The following is a description of a gene set: species: Homo sapiens Any process that results in a change in state or activity of a cell or an organism (in terms of movement, secretion, enzyme production, gene expression, etc.) as a result of a stimulus reflecting the presence, absence, or concentration of oxygen. Human Gene Set: GOBP_RESPONSE_TO_OXYGEN_LEVELS, and this is the list of marker genes: WTIP, MAP3K7, BMP7, MIR34A, LOXL2, CIAO3, NDRG1, TGFBR3 (NCBI Gene Id 7049), FZD4, FMN2, ACAA2, SCAP, MDM4, BNIP1, VEGFC, DRD2, ANGPT2, TBL2, EP300, NOS1, VEGFB, MT-CO1, PGF, ITPR1, LCN2, ANGPT4, DIO3, CAPN2, PTPN1, POLB, SLC11A2, F7, TGFB2, HMOX2, NOTCH1, ADA, DDAH1, BIRC2, INHBA, TFRC, TMBIM6, PML, CAV3, ADSL, TRPC6, HP1BP3, PPARG, CYBA, BECN1, CPEB4, COMT, COL1A1, PDK3, COMMD1, SLC29A1, TMEM199, LMNA, MT-ND1, DPP4, E2F1, RORA, VEGFA, FOXO1, ADORA1, BCL2, AK4, BNIP2, HIGD1C, HYOU1, PRKAA1, MAP1LC3A, EGR1, ADO (2-aminoethanethiol dioxygenase), HSP90B1, MGARP, CD38, CRYAB, SMAD3, MIR223, PLEKHN1, CREBBP, SOD2, PARP2, SCN2A, STUB1, MIR448, ALAS1, MTOR (NCBI Gene Id 2476), CCNA2, MTCO2P12, NGB, BAD, CA9, RYR1 (NCBI Gene Id 906), VASN, TH, ERO1A, S100B, HIF3A, PLAT, MIR214, ENDOG, AQP1, SLC2A8, PENK, CBS, ITGA2, SIRT2, PKLR, UCN3, TNF, ABCB1, ADAM15, FAS, CASP3 (caspase 3), SLC2A4, FGFR2, RPTOR (NCBI Gene Id 654218), BNIP3L, TP53, HIGD1A, MSTN, ATP1B1, CREB1, IRAK1, MALAT1, MIR762, APAF1, CBFA2T3, CYP1A1, MB, PRKCE, ARNT, CASR, DNMT3A, P2RX3, SLC8A3, CHRNA4, TSC1, HSD11B2, TGFB3, TREM2, LTA, CCDC115 (NCBI Gene Id 84317), NDNF, KCNJ8, MDM2, KCNMA1, CHCHD2 (NCBI Gene Id 92547), MIR140, SLC2A1, MT-CO2 (NCBI Gene Id 4513), MYB, JUND, TERT, MT-ND2, NF1 (NCBI Gene Id 646021), OPRD1, CAV1, NOL3, ZEB2, CAT, CPT1A, KCNK3, MIR21, VEGFD, PIK3CB, MYC, ABAT, CLDN3, UBQLN1, EEF2K, ALAS2, SLC6A4, DDR2, MIR210, BNIP3, RWDD3, CXCL12, TWIST1, NDP, CYB5R4, LIMD1, SMAD4, DPM1, ENSG00000274276, PAK1, EPO, CPEB2, ASCL2, AIFM1, ANKRD1, FOXO3, PINK1, PDK1, ATF2, GUCY1B1, CHRNB2, FOSL2, BBC3, CCNB1, USP19 (NCBI Gene Id 10869), CLCA1, AGTRAP, MIR20A (NCBI Gene Id 406982), REST, PPARA, SIRT4, NPPC, SRF, FABP1, NPEPPS, SDHD, AJUBA, EPHA4, ATP6V0D1, PTGS2, ADAM8, PLAU, UCP3, SLC1A1, GNGT1, NONO, PTGIS (prostaglandin I2 synthase), GATA6, ENO1, CPEB1, ATP6V1A, LEP, TRPV4, DRAM1, ANGPTL4, MIR146A, CHRNA7, ALKBH5, ARNT2, MAP2K1, THBS1 (thrombospondin 1), KCNK2, RTN4, SUV39H1, NDUFS2, STAT3, ATP6V1G1, HIF1A, SFRP1, RGCC, ROCK2, HILPDA, PGK1, MTHFR, STC2, CASP9, CFLAR, TM9SF4, LIF (NCBI Gene Id 3976), PLOD1, MYOCD, HSF1, EGLN2, UCP2, TXNRD2, WDR83, ADAM17, MPL, FOS, ANG, SIRT1, SLC9A1, EPAS1, NKX3-1, PPARD (peroxisome proliferator activated receptor delta), TIGAR, GUCY1A1, AKT1, TERC, NOX1, NOS2, USF1, P4HB, FAM162A, KCNJ11, CRYAA, CXCR4, LPAR1, ATF4, PDLIM1, HK2, EGLN3, TGFB1, ATP6AP1, SUV39H2, PICK1, CD24, MYOD1, CITED2, TFAM, MLST8, MMP14, PLOD2, PSEN2, BMP2, MIR145, ERCC2, MT-CYB, ZFP36L1, MIR106B, FIS1, POSTN, MT-ATP6, KCND2, KCNA5, HSPG2, NR4A2, MT-ND4, VCAM1, FUNDC1, EDN1, SOX2, EGLN1, MIR17, ABCC9, ITPR2, NOP53, GUCY1A2, CBL, ATP6V0A2, MT-ND5, DDIT4, SLC7A5, COL6A1, ADIPOQ, STC1, CYBB, MT3, HDAC2, MMP2, SOD3, P2RX2, AGER, NPPA, ATG7, ALAD, UCK2, MECP2, LONP1, AQP3, ENG, VHL, PIN1, CYGB, RYR2, EDNRA, NFE2L2, PMAIP1, HIPK2, RAD21